Given this list of marker genes ACAT1, MMUT, PPCS, HSD17B12, MPC2, PPT1, GCDH, PDHA1, ACLY, ACSL1, DLD, ACSF3, ELOVL7 (NCBI Gene Id 79993), PDK3, BCKDK, ACSS2, PDHB, PDHA2, TPK1, ELOVL3, PDK2, SNCA, SLC27A2, ELOVL1, ACSBG2, ACSL6, PDK1, CBR4 (NCBI Gene Id 84869), ACSL5, ACSS1, ACSL4 (acyl-CoA synthetase long chain family member 4), DLAT, DIP2A, ELOVL4, HACD2, HTD2, ELOVL5, PDHX, ELOVL6, ELOVL2 (ELOVL fatty acid elongase 2), ACACA, HACD1, PPT2, PDK4, ACSL3, MLYCD, ACSBG1 (acyl-CoA synthetase bubblegum family member 1), FASN, PGK1, ACACB, TECR, here is a description of the gene set: The chemical reactions and pathways resulting in the formation of a thioester, a compound of general formula RC(=O)SR' in which the linking oxygen in an ester is replaced by a sulfur atom. They are the product of esterification between a carboxylic acid and a thiol. Human Gene Set: GOBP_THIOESTER_BIOSYNTHETIC_PROCESS studied in species Homo sapiens